Given this list of marker genes SELE, RHOA, NFAT5, CCR2, MIR21, MDK, CHST4, ITGA4, FUT4, FUT7, CHST2 (NCBI Gene Id 96111), SELP, GCNT1, IRAK1, ELANE, ALOX5, ST3GAL4 (NCBI Gene Id 80040), MIR92A1, TRAF6, RELA, ITGB2, TNF, ETS1, IL6, here is a description of the gene set: Human Gene Set: GOBP_POSITIVE_REGULATION_OF_LEUKOCYTE_ADHESION_TO_VASCULAR_ENDOTHELIAL_CELL Any process that activates or increases the frequency, rate or extent of leukocyte adhesion to vascular endothelial cell. studied in species Homo sapiens